Given this list of marker genes Acp5, Tnfrsf14, Kdelr1, Dennd1b, Mif, Card9, Il18, Gorasp2, Ifnb1, F2rl1, Nr4a3, Bcl6, Sema7a, Map3k7, Ticam1, Psen2, Ffar3, Trim6, Bst2, Rsad2, Smad7, Casp4, Tgfb3, Twist2, Wnt5a, Clnk, Syk, Cd226, Htr2a, Cd81, Arid5a, Xcl1, Clec7a, Sash3, Cd74, Fcer1g, Epg5, Axl, Panx1, Il1r1, Il4, Cd55b, Il18r1, Ffar2, Nod1, Laptm5, Rasgrp1, Hk1, Apoa1, Atg5, Lacc1, Sucnr1, Tnf, Il21, Myd88, Il25 (interleukin 25), Lilrb4a, Tirap, Kit, Il31ra, Lilrb4b, Dhx36, Fzd5, Twist1, Tek, Slamf1, Tnfsf4, Mapkapk2, Ifng, Nod2, Fcer1a, Gba1, Inava, Dlg1, Irf5, Il1b, Tlr7, Traf3ip2, Tnfrsf1b, Slamf9, Cd55, Rtn4, Tbx21, Irak3, Scimp, Psg22, Tlr2, Ddx1, Ccr2, Hspa12a, Gimap5, Prg2, Vsir, Cd160, Nlrp3, Gas6 (NCBI Gene Id 14456), Angpt1, Plcg2, Ripk2, H2-T23, Trpm4, Tlr9, Slc11a1, Sirt1, Litaf, Pkp3, Trim55, Tril (TLR4 interactor with leucine-rich repeats), Cd36, Malt1, Trem1, Tlr3, Atg9a, Klrh1, Trem3, Ccl20, Casp1 (caspase 1), Gimap3, Cuedc2, Rigi, Prkcz, Il18rap, H2-M3, Ddx21, Fosl2, Il12a, B2m, Il12b, Calhm6, Epx, Cd96, Jak3, Nlrx1, Ube2j1, Spon2 (NCBI Gene Id 76474), Arg1, Hfe, Stard7, Il10, Apoa2, Traf6, Crlf2, Tlr4, Gata3, Sphk2 (sphingosine kinase 2), Tgfb2, Ash1l, Rabgef1, Hmox1, Gprc5b, Mavs, Traf2, Tgfb1, Pycard (PYD and CARD domain containing), Mir324, P2rx7, Foxp3, Mr1, Il6, here is a description of the gene set: The appearance of a cytokine due to biosynthesis or secretion following a cellular stimulus contributing to an immune response, resulting in an increase in its intracellular or extracellular levels. Mouse Gene Set: GOBP_CYTOKINE_PRODUCTION_INVOLVED_IN_IMMUNE_RESPONSE species: Mus musculus